The following is a description of a gene set: Apoptotic cleavage of cellular proteins Mouse Gene Set: REACTOME_APOPTOTIC_CLEAVAGE_OF_CELLULAR_PROTEINS species: Mus musculus, and this is the list of marker genes: Acin1, Birc2, Fnta, Ptk2, Tjp2, Lmnb1, Add1, Stk24 (serine/threonine kinase 24), Dsg3, Casp7 (caspase 7), Casp6, Sorbs2, Apc, Mapt, Dsg2, Sptan1, Satb1, Dsp, Clspn, Prkcd, Ocln, Casp3, Bmx, Tjp1, Pkp1, Plec, Prkcq, Dsg1a, Casp8, Bcap31, Stk26 (NCBI Gene Id 70415), Gas2, Lmna, Vim, Rock1, Ctnnb1, Gsn